The following is a description of a gene set: studied in species Homo sapiens Any process that activates or increases the frequency, rate or extent of non-motile cilium assembly. Human Gene Set: GOBP_POSITIVE_REGULATION_OF_NON_MOTILE_CILIUM_ASSEMBLY, and this is the list of marker genes: SEPTIN7, WRAP73 (NCBI Gene Id 55648), CEP135, SEPTIN9, ATMIN, HAP1, CENPJ, TTBK2 (tau tubulin kinase 2), RP1